Given this list of marker genes Gbp2, Ly6a, Cd8b1, Zfp593, Ifi27l2a, H2-T22, Igfbp4, here is a description of the gene set: Cytokines mediate cell-cell communication in the immune system and represent important therapeutic targets. A myriad of studies have highlighted their central role in immune function, yet we lack a global view of the cellular responses of each immune cell type to each cytokine. To address this gap, the authors created the Immune Dictionary, a compendium of single-cell transcriptomic profiles of more than 17 immune cell types in response to each of 86 cytokines (>1,400 cytokine-cell type combinations) in mouse lymph nodes in vivo. A cytokine-centric view of the dictionary revealed that most cytokines induce highly cell-type-specific responses. For example, the inflammatory cytokine interleukin-1β induces distinct gene programmes in almost every cell type. A cell-type-centric view of the dictionary identified more than 66 cytokine-driven cellular polarization states across immune cell types, including previously uncharacterized states such as an interleukin-18-induced polyfunctional natural killer cell state. Mouse Gene Set: CUI_B_CELL_IFNL2_RESPONSE_UP from publication Cui A, Huang T, Li S, Ma A, Pérez JL, Sander C, Keskin DB, Wu CJ, Fraenkel E, Hacohen N (PMID 38057668) Genes positively differentially expressed in cell type: B cell upon treatment with cytokine: IFN-λ2 in mouse lymph nodes in vivo. studied in species Mus musculus